Given this list of marker genes IL1B, PYCARD, IL18, NLRP12, CASP1, here is a description of the gene set: Pathway Definition from KEGG: (NLRP12+PYCARD) -> CASP1 -> (IL1B,IL18) studied in species Homo sapiens Human Gene Set: KEGG_MEDICUS_REFERENCE_NALP12_INFLAMMASOME_SIGNALING_PATHWAY NALP12 inflammasome signaling pathway. Pathway ID: N01569. Pathway type: Reference. Pathway class: nt06521 NLR signaling.